Given this list of marker genes Chrna7, Git1, Lilrb4a, Elf4, Rad21, Errfi1 (ERBB receptor feedback inhibitor 1), Cptp, Acp5, Pml, Spag11a, Zc3h12a, Ghsr, Gstp3, Serpinb1c, Ffar4, Arrb2, Ghrl, Igf1, Gstp2, Nlrc3, Aqp4, Nlrp3, Trem2, Ffar1 (free fatty acid receptor 1), Serpinb1b, Apoa1, Tnfaip3, Gstp1, Mefv, Serpinb1a, Lilrb4b, Gstp-ps, Cx3cr1, here is a description of the gene set: Any process that stops, prevents, or reduces the frequency, rate, or extent of interleukin-1 beta production. studied in species Mus musculus Mouse Gene Set: GOBP_NEGATIVE_REGULATION_OF_INTERLEUKIN_1_BETA_PRODUCTION